Given this list of marker genes Eif4a3l1 (NCBI Gene Id 671719), Eif4a3l2, Eif4e, Eif4a3, Cyfip1, Fmr1, here is a description of the gene set: Mouse Gene Set: GOBP_REGULATION_OF_TRANSLATION_AT_POSTSYNAPSE_MODULATING_SYNAPTIC_TRANSMISSION Any process that modulates synaptic transmission by regulating translation occurring at the postsynapse. species: Mus musculus